The following is a description of a gene set: A proton-transporting two-sector ATPase complex that catalyzes the phosphorylation of ADP to ATP during oxidative phosphorylation. The complex comprises a membrane sector (F0) that carries out proton transport and a cytoplasmic compartment sector (F1) that catalyzes ATP synthesis by a rotational mechanism; the extramembrane sector (containing 3 a and 3 b subunits) is connected via the d-subunit to the membrane sector by several smaller subunits. Within this complex, the g and e subunits and the 9-12 c subunits rotate by consecutive 120 degree angles and perform parts of ATP synthesis. This movement is driven by the hydrogen ion electrochemical potential gradient. species: Mus musculus Mouse Gene Set: GOCC_PROTON_TRANSPORTING_ATP_SYNTHASE_COMPLEX, and this is the list of marker genes: Atp6-ps, Atp5f1e, Atp5f1d, Atg5lrt, Atp5f1b, Atp5mc1, Atp5mf, mt-Atp8, Atp5mc2, Atp5pd, Atp5mk, Atp5mc3, Atp5f1a, Atp5po, mt-Atp6, Atp5me, Dmac2l, Atp5pf, Atp5f1c, Atp5mj, Atp5mg, Atp5pb